The following is a description of a gene set: The process whose specific outcome is the progression of the telencephalon over time, from its formation to the mature structure. The telencephalon is the paired anteriolateral division of the prosencephalon plus the lamina terminalis from which the olfactory lobes, cerebral cortex, and subcortical nuclei are derived. Mouse Gene Set: GOBP_TELENCEPHALON_DEVELOPMENT studied in species Mus musculus, and this is the list of marker genes: Mfsd2a (NCBI Gene Id 76574), Csf1r, Ncoa1, Bcan, Mme, Sec1, Mecp2, Zic3, Aqp1, Fbxo41, Atp1a3, Rtn4rl1, Kif14, Lhx1 (LIM homeobox protein 1), Atp2b4, Cxcl12, Tmem108 (transmembrane protein 108), Ascl1, Csnk2a1, Pals1, Plxna4, Oxtr, Pex5, Rara, Rhoa, Shank3, Ppp1r9b (protein phosphatase 1, regulatory subunit 9B), Ezh2, H2ax, Fxr1, Tctn1, Zeb2, Zdhhc16, Rtn4rl2, Lhx2, Cdk5r2 (NCBI Gene Id 503689), Nrg3, Ntrk2, Zic1, Secisbp2, Zbtb18 (NCBI Gene Id 30928), Nrg1, Bloc1s6, Bmerb1, Atg7, Cntn2, Draxin, Ctnnb1 (catenin beta 1), Slitrk5, Lrp6, Uqcrq, Hes1, Bhlhe22, Trappc9, Efna2, Ccdc39, Tfap2c, Robo2, Atat1, Dab2ip, Sema7a, Hdac2, Tacc1, Dbi, Filip1, Pcnt, Chd7, Slc32a1, Lypd6, Gart, Sox2, Gria1, Szt2, Mir376a, Crkl, Tbr1, Atp1a2, Scn2a (NCBI Gene Id 241424), Slc7a11, Plcb1, Eomes, Avpr2, Atp1b2, Tacc2, Six3 (sine oculis-related homeobox 3), Mir9-2, Psen1, Pafah1b1, Tacc3, Kcna3, Prox1, Pianp, Numbl, Myh10 (myosin, heavy polypeptide 10, non-muscle), Kif3a, Atf5, Dclk2, Neurod1, Fbxo45, Nsun5, Hdac1, Dlx2, Mir9-3 (NCBI Gene Id 723968), Flna, Cul5, Foxb1, Ccdc141, Fezf2, Htt, Grcc10, P2ry12, Foxg1, Mgarp, Btg2, Mir429, Lrp8, Alk, Cxcr4, Fezf1 (NCBI Gene Id 73191), Dab1, Htr5a, Mkks, Cdk5, Lhx5, Mir200b, Crtac1, Drd2, Mcph1, Kif21b, Ryk, Usp9x, Pfdn1, Dmd, Slit1, Gli3, Kcna2, Bbs1, Wdr37, Xrcc1, Emx1, Ift88, Syne2, Foxp2, Bbs2, Igf2bp1, Fez1, Pomt2, Kdm6b, Uba6 (ubiquitin-like modifier activating enzyme 6), Kdm2b, Dicer1, Dixdc1, Tsku, Zswim6, Drd1, Ccdc85c, Numb, Cep120, Hprt1, Disc1, Id2, Lrrk2, Ndel1, Hnrnpk, Shh, Tubb2a, Efhc1, Mdga1, Mir9-1, Fut1, Ulk4 (NCBI Gene Id 74372), Fxr2, Smo (NCBI Gene Id 319757), Fat4, Crk, Bmp2, Wdr47, Kif26a, Arx, Dcx, Rtn4, Rtn4r, Kcna1, Rarb, Sall1, Pomgnt1 (protein O-linked mannose beta 1,2-N-acetylglucosaminyltransferase), Htr6, Zmiz1, Mir141, Pou3f2, Herc1, Bax, Kcnc1 (NCBI Gene Id 320399), Sall3, Ephb2 (NCBI Gene Id 13844), Wnt3a, Pou3f3, Ncor2, Cdh2, Mdk, Ywhae, Grin1, Nr4a3, Ext1, Kcnq2, Ephb3, Atg16l1, Nf1, Tubb2b, Srf, Phactr1, Npy, Anxa3, Sun1, Srd5a2, Adgrg1, Eif2b5, Kirrel3, Tnr, Kat2a, Dlx1, Fgf13, Sun2, Wdr62, Slc2a1, Plxna3, Avpr1a, Fos, Lhx6, Nf2, Celf1, Cdk5r1, Inhba, Nfix, Srgap2, Fgf8, Ogdh, Egfr, Tra2b, Rpgrip1l, Gmppa, Nefl, Fktn, Kdm1a, H2aj, Epha5, Large1, Lamb1, Nars1, Cdon, Dpcd, Mas1, Hif1a (NCBI Gene Id 15251), Trp73, Xrn2, Bmp4, Nkx2-1, Btbd3, Erbb4, Casp3, Wnt5a, Slc38a2, Fut10, Lpar1, Hes5, Atic, Ttc8, Pten, Mboat7, Bnip3, Mir200a, Reln, Bbs4, Dlx5, Robo1, Pex13, Uchl5, Nr2e1, Sct, Otx2, Prdm8, Arl13b, Mir200c, Emx2, Slc1a2, Id4, Dmxl2, Lef1 (lymphoid enhancer binding factor 1), Afdn, Dmrta2, Pax5, Aspm, Rac1, Th, Nfib, Rfx4, Lmx1a, Atoh1, Vps13b, Wdr89, Ski, Pax6, Abcc1, Col3a1, Akirin2 (akirin 2), Nin, Aldh1a3, Nr2f1, Nde1, Ptprs, Tsc1, Agtpbp1, Sema3a, Slit2, Rnf7, Gsx2 (NCBI Gene Id 14843), Neurod6 (neurogenic differentiation 6), Dnah5, Socs7, Uncx, Fgfr1, Gsk3b, Sema6b, Tuba1a, Bcl11b, Coro1c